The following is a description of a gene set: Mouse Gene Set: GOBP_NEGATIVE_REGULATION_OF_SMOOTHENED_SIGNALING_PATHWAY Any process that stops, prevents, or reduces the frequency, rate or extent of smoothened signaling. species: Mus musculus, and this is the list of marker genes: Rfx4, Gpr161, Serpine2, Wnt7b (wingless-type MMTV integration site family, member 7B), Gas1, Prkacb, Gli3, Ift172, Gpr37l1, Prkaca, Enpp1, Cd3e, Sufu, Megf8, Ulk3, Kif7, Sall3, Traf3ip1, Fgfr3, Hhip, Mgrn1, Glis2, Gpc3, Cdk20, Mosmo, Gli2, Vcp, Ift122, Sall1, Tulp3, Tmed2, Ptch2, Rack1 (NCBI Gene Id 14694), Runx2, Kctd6, Ubr5, Kctd21, Ptch1, Rb1, Kctd11, Herc4